Given this list of marker genes Zfp708 (zinc finger protein 708), Polr1e, Tdg (NCBI Gene Id 21665), Npas4, Map2k6, Zfp1, Zfp112, Phf20l1, Zfp688, Mre11a, Gtf2a1, Runx2, Gm14391, Cox6a1, Psmd13, Ppp2r1b, Gata1, Mapk11, Krba1, Zfp786, Polr2l, Actl6b, Tnks1bp1, Ints10, H4c12, Hdac7, Cited4, Gtf3c5, H2ac13, Gm45871 (NCBI Gene Id 108168395), Taf9b (TATA-box binding protein associated factor 9B), Elf1, H2ac1, Zfp473, Srrt, Zfp938, Zfp872, Cnot10 (NCBI Gene Id 78893), Psma3, Mbd3, Rad1, Smarcd1, Aurkb, Gtf3c6, Nr5a1, Scmh1, Polr3c, Supt5, H3c7, Cbfb, Polr2f, Cul1, Cnot7, Zfp324, Zfp661, Tarbp2, Mapkapk5 (NCBI Gene Id 17165), Wwtr1, Cga, Wdr82 (NCBI Gene Id 77305), Supt4a, H3c2, Polr2a, Zfp617, Zfp605, Pou4f2, Rabggta, Taf4b, Zfp934, H2ac22, Zfp647, Mllt1, Taf1d, Taf1, Zfp995, H2ax, Polr3e, Zim1, Ing2, Foxp3, Ints13, Zfp69, Nuak1, Zfp354b, AI987944, Casp2, Nr2f1, Polr2b, Snw1, Zkscan17 (NCBI Gene Id 268417), Zfp825, Zfp383, Tcf7l2, Prkag3, H4c6, Zfp759, Zfp595, Gtf2e2, Zfp992, Gadd45a, Smurf2, Zfp987, Ints7, H2ac6, Blm, Hdac11, Gm10033, Zfp175, Cox6a2, Csnk2b, H4c9, Zfp454, Polr2e, Zfp65, Zfp212, Gm7072, Ran, Gps2, Zfp493, Ppp1r13b, Psmc4, Cdk8, Zfp691, Zfp286, Ercc3, Cdk1, Zfp455, Cited1, Ccng1, Sin3a, Cdkn1a, Tgif1, Zfp74, Zfp418, Rngtt, Banp, Lamtor2, Ubb, Ctr9, Zfp784, Sgk1, Esrrg, Psma1, Prkag1, Ldb1, Psma6, H2ac4, Tal1, Med1, Zfp583, Cdk13, Trp63, Zfp446, Zfp551 (NCBI Gene Id 619331), Rpa1, Zfp141, Txn1, Cbx2, Zfp606, Cox8a, Nr3c1, Ep300 (NCBI Gene Id 328572), Ddx21, Hnf4g, Zfp747, Sesn2, Zfp867, Notch3, Ice2, Psmd12, Zfp612, Ezh2, Gtf2h4, B020011L13Rik, Prelid1, Zfp273, Psmb5, Cbx4, Psmb7, Pcna, Cox5a (NCBI Gene Id 12858), H2bc15, Prdx1, Zkscan4 (zinc finger with KRAB and SCAN domains 4), Clp1 (NCBI Gene Id 98985), Polr2c, Ccne1, H2ac10, Brca1, Zfp930, Zfp37, Cox4i1, H4c18, Rheb, H3c6, H2ac8, Polr3d, Cnot4, Nr0b1, Zfp772, H3c13, Zfp959, Polr2i, Zfp955a, Steap3, Snapc1, Cpsf1, Tgfb1, Lmo2, H2az2, Ercc2, Psmc1, Phf20, Foxo6, Snrpg, Bax, Zfp169, Nr4a3, H2bc11, H2bc13, Trp53, Zfp775, Hdac4, Iws1, Zfp61, Ctdp1, Zfp764, Gtf2h2, Zfp14, Gtf2f2, H2ac20, Leo1, Psmb6, Brpf3, Tpx2, Zfp955b, Taf15, Psmd6, E2f7, Ccnb1, Zfp990, Gata3, Lsm11, Zfp94, Aff4, Zfp429, Pparg, Cdk12, Zfp27, Rxrg, Wrn, Rnf111, Zfpm1, Bmal1, H2ac12, Zfp667, Zfp712, Zfp964, Taf5, Gpx2, Smarcc1, H2bc22, Tfap2d, Myc, Kmt2b, Cdc25c, Tbl1x, Ube2d1, H4c2, Tbx5, Zfp202, Zfp946, L3mbtl2, Ctnnb1, Rabggtb, Zfp58, Cbx8, Zfp677, Ring1, Thrb, Hnf4a, Smad1 (SMAD family member 1), Rictor, Dnmt1, Nr2f6, Cradd, H4c4, Higd1c, Rraga, Gtf2b, Cbx6, Taf7l, H4c1, H3c15, Ar, Igfbp3, Smarcd2, Vdr, Polr3h, Cox6c, Zfp600, Prdm9, Gm4924, Zfp799, H2ac11, Zfp808, Rorb, Hdac8, Zscan25, AU041133, Psma7, H4c17, Zfp942, H4c14, Zkscan3, Tcf7l1, Cpsf3, Dna2, Taf6, Zfp750, H3c1, Zfp947, Zfp735, H3c10, Nbn, Ncor2, Rpap2, H4c8, Zfp39, Rad9a, Zfp982, Brpf1, Psma4, Kansl2, H2ac24, Paxip1, Nr0b2 (nuclear receptor subfamily 0, group B, member 2), Nelfa, Hdac3, Mapk14, Pou2f2, Zfp101, Tfam, Nek4, Lamtor4, H2bc12, Pip4p1 (NCBI Gene Id 219024), Tnrc6c, Taf10, Setd1a, Snapc3, Pou2f1, Gtf3c1, Zfp811, Ints1, Slbp, Max, Zfp931 (zinc finger protein 931), Zik1, Nelfe, Tada2a, Wdr33, Lbr, Gtf2f1, Zfp738, Zfp457, Nr4a1, H3c3, H3c4, Bard1, Zfp386, Mybbp1a, Hus1, Ddit4, Ndufa4, Zfp113, Foxo4, Zfp90, H2ac7, Psmc3, Atp1b4, Zfp445, Cox8c (NCBI Gene Id 75483), Sfn (stratifin), Mta2, H3f3a, Pax5, Zfp458, Daxx, Pip4k2c, Zfp35, Zfp317, Zfp839, Pcgf2, Rnmt, Lamtor1, Ccnd1, Taf13 (TATA-box binding protein associated factor 13), Gtf2e1, Zfp943, Cdk5, Psmc6, Ago4, Psma5, Zfp991, Kat5, Gata2, Papola, Tcea1, Cox7c (cytochrome c oxidase subunit 7C), Triap1, Zfp566, E2f6, Tead2, Psmd7, Zfp770, Ints8, Zfp703, Pdpk1, Esrrb, Supt16, Ccnh, Zfp715, Cox7a2l, Hcfc2 (host cell factor C2), Nabp2, H4c3, Zfp354a, Ywhah (NCBI Gene Id 22629), Bmi1, Nr1d2, Zfp994, Zfp46, H2bc9, Cdkn1b, Smarca2, Serpinb13, Zfp729a, Rxrb, Zfp268, Yaf2, Gtf3c2, Ywhae, Tcf7, Plk2, Zfp385a, Rarb (NCBI Gene Id 218772), Polr3g, Polr2k, Zfp804b, Maged1, Psma2, Zfp456, Lamtor5, G6pdx, Tfap2e, Fip1l1 (NCBI Gene Id 66899), Smad3, Nr1i2, Ercc6, Nrbf2, Smarcb1, Zkscan5, H2bc1, Sirt1, H2bc8, Prdx5, Hcfc1, Rorc, Rbbp4, Smarca4, Zfp746, H2ac19, Zfp874b, Ccna1, Zfp655, Psmb4, Chek2, Esr2, Eaf2, Ppp1r13l, H3c8, Arid1a, H2bc27, Cited2, Zfp119b, Nr1h4, Cenpj, Tead4 (NCBI Gene Id 21679), Tfap2a, H2bc7, Prmt5, Kansl1, Snrpf, Smurf1, Trp73, Txnrd1, Ppm1d, Zfp763, Rragc, Nr4a2, Zfp12, Cycs, Polr1c, Arnt2, Zfp420, Zfp791, Psmc2, Tcf3 (transcription factor 3), Cdk4, Atad2, Rara, Zfp940, Zfp619, Pcgf6, Esr1, Zfp582, Mta1, Rfc3, Nr2c2, Taf11, Taf8, Tfdp1, Ezh1, Cox7a1, Zfp989, Zfp758, Zfp747l1, Polr1g, Dyrk2, Ash2l, Sgf29, Eaf1, Rarg, Tbp, Cox4i2, Zfp740, Zfp641 (zinc finger protein 641), Zfp971, Ints2, H4c11, Gm5141, Zfp689, Rps27a, Hdac10, H2bc3 (NCBI Gene Id 319178), Dnmt3b, Npm1, Polr1h, Gls2, Phc1, Sumo1, Bdp1, Smarca5, Mapk3, Zfp788, H2ac15, Psmc5, Smarcc2, Rbbp7, Psmd1, Kdm6a, Yap1 (yes-associated protein 1), Taf12, Crcp, Smad7, Ell2, Zfp263, Ccne2, Zkscan8, Gm14325, Ints14, Tsc1, Taf7, Men1, Top3a, Rsl1, Nr2e1, Rbbp8, Ehmt1, H3c11, Zkscan7, Gtf3c3 (NCBI Gene Id 98488), H2ac23, here is a description of the gene set: electronically inferred by orthology from the curated human pathway species: Mus musculus This event has been computationally inferred from an event that has been demonstrated in another species.<p>The inference is based on the homology mapping from PANTHER. Briefly, reactions for which all involved PhysicalEntities (in input, output and catalyst) have a mapped orthologue/paralogue (for complexes at least 75% of components must have a mapping) are inferred to the other species. Reactome Pathway: Gene expression (Transcription)